Given this list of marker genes LMNA, GDF5, VAC14, BMPR1B, EOGT, FIG4, KCNN3, TBX5, here is a description of the gene set: species: Homo sapiens Aplasia of the phalanges of the toes Human Gene Set: HP_APLASIA_OF_THE_PHALANGES_OF_THE_TOES Absence of a digit or of one or more phalanges of a toe.